The following is a description of a gene set: studied in species Homo sapiens Human Gene Set: WP_HUNGER_AND_SATIETY Hunger and satiety, and this is the list of marker genes: GCG, PYY, LEP, POMC, NPY, GHRL, MC4R, AGRP